Given this list of marker genes RRAGD, AKT1S1 (NCBI Gene Id 84335), FLCN, TELO2, DEPTOR, RRAGB, MLST8, SLC3A2, RPTOR, MTOR, SLC7A5, RRAGC, TTI1, RRAGA (Ras related GTP binding A), here is a description of the gene set: Human Gene Set: KEGG_MEDICUS_REFERENCE_FLCN_MTORC1_SIGNALING_PATHWAY Pathway Definition from KEGG: (SLC7A5+SLC3A2) -> FLCN -> (RRAGA+RRAGB+RRAGC+RRAGD) -> mTORC1 FLCN-mTORC1 signaling pathway. Pathway ID: N01584. Pathway type: Reference. Pathway class: nt06522 mTOR signaling. species: Homo sapiens